Given this list of marker genes SLC30A2, SLC30A5, SLC30A3, SLC30A8, SLC30A1, here is a description of the gene set: Human Gene Set: REACTOME_ZINC_EFFLUX_AND_COMPARTMENTALIZATION_BY_THE_SLC30_FAMILY Zinc efflux and compartmentalization by the SLC30 family studied in species Homo sapiens